The following is a description of a gene set: Myeloid-derived cells comprising the tumor stroma represent a heterogeneous population of cells critical to the structure, function and growth of established cancers. We have recently found that engineering tumor-specific CD8+ T cells to secrete IL-12 (IL-12TD) can lead to striking improvements in T-cell activity against established melanomas in murine models. Surprisingly, IL-12-dependent enhancement of CD8+ T-cell anti-tumor function did not occur through direct ligation of receptors on lymphocytes or NK cells. Instead, IL-12 sensitized host bone marrow-derived tumor-stromal cells, partly through interferon-gamma, to indirectly enhance the effects of adoptively-transferred T cells. Direct presentation of antigen by tumor was not necessary, but MHC class I expression on endogenous cells was essential for IL-12 mediated anti-tumor enhancements. Upon successful treatment with IL-12TD cells, we observed the selective elimination of tumor-infiltrating CD11b+ F4/80+ macrophages, CD11b+/ClassII+/CD11c+ dendritic cells and CD11b+/Ly6C+/Ly6G- but not CD11b+/Ly6C+/Ly6G+ myeloid-derived suppressor cells within regressing lesions. These results are consistent with a model whereby IL-12 triggers the maturation of myeloid-derived cells into competent antigen cross-presenting cells. Licensed recognition of these antigens by effector T cells may in turn trigger the collapse of the tumor stroma and aid in the regression of large vascularized lesions. from publication Kerkar SP, Goldszmid RS, Muranski P, Chinnasamy D, Yu Z, Reger RN, Leonardi AJ, Morgan RA, Wang E, Marincola FM, Trinchieri G, Rosenberg SA, Restifo NP (PMID 22056381) studied in species Homo sapiens Genes down-regulated in untreated B16 melanoma: day 3 versus day 7. Human Gene Set: GSE29164_DAY3_VS_DAY7_UNTREATED_MELANOMA_DN, and this is the list of marker genes: FAM162A, SEMA6D, KCTD6, FNBP1L, SSR4, METRN, SPCS3, LY96, ERP44, SPOP, CTNND1, G3BP2, GALK1, ERBIN, NAB2, BBS12, RBPJ, GAS8, CLCN6, POLR1E, CISD3, MOSPD2, SEPTIN9, B3GNT5, LRRC1, TXNDC5, IK, TENT2, SNHG6, C1orf131, SDF2L1, TRAPPC4, IL15, ANO6, RIOX1, FAM91A1, ADAM8 (NCBI Gene Id 101), ISCA2, MCRIP2, SLC11A2, P2RX7, ITGA6, UBASH3B, NDUFA1, TYK2, FXYD5, MTHFD2L, PHKA2, CHST11 (carbohydrate sulfotransferase 11), UAP1L1, DPAGT1, SCARB2, C2orf69, DMAC1, UBTD2, STT3A, MRPL18, CSTB (NCBI Gene Id 1476), ACYP1, LSR, TIAM1, STX17, DENND1B (NCBI Gene Id 54530), RTCB, CREB3, BIVM, RTL8B, SEC24D, SLC33A1, EPRS1, OSBPL9, GNA15, NDUFB2, VPS41, MID1IP1, SPTBN1, DOCK7, NCKIPSD, KCTD10, ELAC2, KIF2A, SLC35A2, FUNDC1, RHEBL1, RTL8C, KRTCAP2, AGPAT3, TLE1, PTGR3, PARP12, CTDSP2, C11orf54, RNF180, FFAR4, RAB19, TMEM128, PLPP2, HMCES, AK3, TOR3A, SDAD1, BID, KCTD14, NUCB2, AKR1A1, CS, CLNK, DNMBP (dynamin binding protein), ACVRL1, YIPF6 (NCBI Gene Id 286451), MYOF, ARID2, PSMA6, CAMK1D, PBX1, TTLL4, HDLBP, TMEM134, ZDHHC23, PTOV1, RAB39A, TMTC3, LRRC3, DICER1, MYO18A, SLK, RNF150, INPP1, ARSB, SELENOS, PRKAB2, GNA11, SLC66A1, TMED10, PCSK5, PREB, GALNT7, NUCB1, VDAC2, ERP29 (endoplasmic reticulum protein 29), ACOX3, UBE2N, VPS37C, CD38, RASA3, WDFY3, OSTC, TPCN2, AMMECR1L, PLBD1, BPNT1, POMP, COA5, THUMPD3, CLDND1, GALNT10, VKORC1L1, PGS1, MCTP1, CD81, ERMARD, MYCBP, SH3BP5L, RAC3, DPY19L1, HIPK2, BATF3, PLEKHA2, PID1, EEFSEC, UQCRC2, ORMDL2, TM4SF5, IFI44, SYNE1, TCTN2 (tectonic family member 2), FNBP1, SLC25A24, DHX32, CYB561, ARL6, TRIB1, SELL, RFXAP, RAB7A (RAB7A, member RAS oncogene family), SCARB1, COPS7A, EVL, SLC39A1, PLPP5, ZFYVE26, RASGRP3, PIANP, CDK2AP2, PDE8A, NUMB, HMGCL, ARHGAP18, ASNS